The following is a description of a gene set: The chemical reactions and pathways involving glycosides, compounds in which a glycosyl group is substituted into a hydroxyl, thiol or selenol group in another compound. species: Mus musculus Mouse Gene Set: GOBP_GLYCOSIDE_METABOLIC_PROCESS, and this is the list of marker genes: Akr1c13, Gla, Akr1cl, Akr1b1, Gba1, Akr1a1, Th, Naga, Fuca2, Gba2, Abhd10, Akr1c12, Akr1c14, Cbr4 (carbonyl reductase 4, NCBI Gene Id 338511), Akr1c6, Akr1c20, Akr1c19, Fuca1, Akr1c18, Akr1c21